The following is a description of a gene set: studied in species Homo sapiens The series of events required for an organism to receive a touch stimulus, convert it to a molecular signal, and recognize and characterize the signal. This is a neurological process. The perception of touch in animals is mediated by mechanoreceptors in the skin and mucous membranes and is the sense by which contact with objects gives evidence as to certain of their qualities. Different types of touch can be perceived (for example, light, coarse, pressure and tickling) and the stimulus may be external or internal (e.g. the feeling of a full stomach). Human Gene Set: GOBP_SENSORY_PERCEPTION_OF_TOUCH, and this is the list of marker genes: KCNA1, P2RX4, KCNK2, RAB3A, TMEM87A, KCNK4